Given this list of marker genes Nup62, Aurka, Ranbp1, Chek1, Nsfl1c, Kif11, Ndel1, Ubxn2b, Cntrob, Nek2, Cep85, Nde1, Kif15, Map9, here is a description of the gene set: species: Mus musculus Mouse Gene Set: GOBP_CENTROSOME_SEPARATION The process in which duplicated centrosome components move away from each other. The centriole pair within each centrosome becomes part of a separate microtubule organizing center that nucleates a radial array of microtubules called an aster. The two asters move to opposite sides of the nucleus to form the two poles of the mitotic spindle.